Given this list of marker genes MAX, MYCN, NTRK1, NGFR, SP1, ZBTB17, here is a description of the gene set: Amplified MYCN to transcriptional repression. Pathway ID: N00132. Pathway type: Variant. Pathway class: nt06240 Transcription. Human Gene Set: KEGG_MEDICUS_VARIANT_AMPLIFIED_MYCN_TO_TRANSCRIPTIONAL_REPRESSION species: Homo sapiens Pathway Definition from KEGG: MYCN* == MAX == (SP1+ZBTB17) => (NTRK1,NGFR)